Given this list of marker genes SAP30, ZNF600, TMEM140, MBD2, FXYD1, SUPV3L1, IL20, DUSP2, EPSTI1, USP45, CCR5 (C-C motif chemokine receptor 5), ISG15, PPP4C, BARX1, ASPH, SIGLEC7, ZUP1, MB, LRBA, CH25H, SLC30A7, H2AC25, FAM174A, CCNL2, BCAS2, OAS3 (NCBI Gene Id 4940), RIPK2 (receptor interacting serine/threonine kinase 2), CHPT1, CCDC86, LLGL1, FAM13B, CYP2F1, IRF2, SELPLG, SMAD1, SPIN1, BCAR3, THAP12, SMAD3, RASA4 (NCBI Gene Id 10156), CD300LF, SYPL1, CAB39L, TSPAN13, PARP12, B4GALT6, CLIP1, MSRA, CLCF1, IRF8, HCK (HCK proto-oncogene, Src family tyrosine kinase), CXCR4, GATAD2A, ARL1, SOX14, RAB18, FGF23, SUMF1, FCGR2B, QKI, NCSTN, CD47, SPOP, STX7, MMP9, HMBOX1, CACNG1, MFSD3, MYOM1 (NCBI Gene Id 8736), TIFA, CEP104, GLIPR2, CASP1, MPP1, GPBP1L1, STK24, ETV1, RAP2C, VAMP8, EIF4ENIF1, CNP, FBXO42, GDA, PGS1, ACTN3, MAK, F7, TBC1D8, CAAP1, RHOH, MCRIP1, PLIN2, BATF3, UAP1, SLC4A8, FYCO1, UIMC1, TLE3, GYPC, CLINT1, CCRL2, KATNA1, DACH1, GORASP2, PLA2G5, KLF2, MED6, EPB41L5, BMP8B, GPR65, FAAP20, BLOC1S6, NAPSA, PFKFB3, SMPD5, PRDM1, CNOT6, DAPP1, TIMM10B, EHD4 (NCBI Gene Id 30844), COPG2, CHMP1A, PLEKHF2, TCF7, MTHFR, ALDH1A2, BFAR, NCF4, SPINT1, SLC25A28, SASH1 (SAM and SH3 domain containing 1), MITD1, USP18, LARGE1, ADAR, DBNL, RNASEK, COPB1, PIAS1, AKT2, MEF2A, SNX10, CXCL10, VBP1, PTGES, CSN3, SAV1, SMC4, STAT4, FBXL6 (F-box and leucine rich repeat protein 6), LTB4R (leukotriene B4 receptor), AP1S2, ARHGAP18, TCTN2, MARCHF5, RTP4, ATF3, GTPBP1, DOCK1, DNAJC10, RBM43, RGS1, FLT3, KCTD14, LMO2, AP1M2, LZTS2, BICDL1, KAT6A, ITPR1, GJA10, TSPYL4, STAG2 (STAG2 cohesin complex component), TRAF1, DEDD, AP3B1, KHDRBS2, CYP17A1, HCAR2, CHRNE, SRD5A3, TSPAN6, CD96, CCR1, IFT172, POLR3C, TMEM229B (NCBI Gene Id 161145), CENPH, KANK2, APOBEC1, ZMIZ2, CMPK2, CASP12, RGS14, LRP5, SLC25A22, GMPPA, SPATA13, GRAMD2B (GRAM domain containing 2B), KEAP1, here is a description of the gene set: Human Gene Set: GSE17721_PAM3CSK4_VS_GADIQUIMOD_4H_BMDC_DN mouse primary BMDCs were stimulated with tlr ligands and gene expression changes were profiled on Affymetrix arrays from publication Amit I, Garber M, Chevrier N, Leite AP, Donner Y, Eisenhaure T, Guttman M, Grenier JK, Li W, Zuk O, Schubert LA, Birditt B, Shay T, Goren A, Zhang X, Smith Z, Deering R, McDonald RC, Cabili M, Bernstein BE, Rinn JL, Meissner A, Root DE, Hacohen N, Regev A (PMID 19729616) species: Homo sapiens Genes down-regulated in comparison of dendritic cells (DC) stimulated with Pam3Csk4 (TLR1/2 agonist) at 4 h versus DC cells stimulated with Gardiquimod (TLR7 agonist) at 4 h.